The following is a description of a gene set: Genes down-regulated in tumorous liver tissues from PARK2 knockout mice compared to the normal, non-tumorous tissue from wild type mice. The parkin was first identified as a gene implicated in autosomal recessive juvenile Parkinsonism. Deregulation of the parkin gene, however, has been observed in various human cancers, suggesting that the parkin gene may be important in tumorigenesis. To gain insight into the physiologic role of parkin, we generated parkin-/- mice lacking exon 3 of the parkin gene. We demonstrated here that parkin-/- mice had enhanced hepatocyte proliferation and developed macroscopic hepatic tumors with the characteristics of hepatocellular carcinoma. Microarray analyses revealed that parkin deficiency caused the alteration of gene expression profiles in the liver. Among them, endogenous follistatin is commonly upregulated in both nontumorous and tumorous liver tissues of parkin-deficient mice. Parkin deficiency resulted in suppression of caspase activation and rendered hepatocytes resistant to apoptosis in a follistatin-dependent manner. These results suggested that parkin deficiency caused enhanced hepatocyte proliferation and resistance to apoptosis, resulting in hepatic tumor development, partially through the upregulation of endogenous follistatin. The finding that parkin-deficient mice are susceptible to hepatocarcinogenesis provided the first evidence showing that parkin is indeed a tumor suppressor gene. from publication Fujiwara M, Marusawa H, Wang HQ, Iwai A, Ikeuchi K, Imai Y, Kataoka A, Nukina N, Takahashi R, Chiba T (PMID 18574468) species: Mus musculus Human Gene Set: FUJIWARA_PARK2_IN_LIVER_CANCER_DN, and this is the list of marker genes: BCL6, ASNS, FST, EIF2S3 (eukaryotic translation initiation factor 2 subunit gamma), NAT8